The following is a description of a gene set: electronically inferred by orthology from the curated human pathway Reactome Pathway: Activation, myristolyation of BID and translocation to mitochondria This event has been computationally inferred from an event that has been demonstrated in another species.<p>The inference is based on the homology mapping from PANTHER. Briefly, reactions for which all involved PhysicalEntities (in input, output and catalyst) have a mapped orthologue/paralogue (for complexes at least 75% of components must have a mapping) are inferred to the other species. studied in species Mus musculus part of: Intrinsic Pathway for Apoptosis, and this is the list of marker genes: Gzmb, Nmt1, Casp8